Given this list of marker genes Dbh (NCBI Gene Id 13166), Th (tyrosine hydroxylase), Ddc, Pnmt, here is a description of the gene set: This event has been computationally inferred from an event that has been demonstrated in another species.<p>The inference is based on the homology mapping from PANTHER. Briefly, reactions for which all involved PhysicalEntities (in input, output and catalyst) have a mapped orthologue/paralogue (for complexes at least 75% of components must have a mapping) are inferred to the other species. species: Mus musculus Reactome Pathway: Catecholamine biosynthesis electronically inferred by orthology from the curated human pathway part of: Metabolism of amine-derived hormones